Given this list of marker genes H2AC4, H4C2 (NCBI Gene Id 8366), H4C16, H4C6, H4C11, H4C14, H4C12, H4C8, H4C15, H4C9, H4C13, H4C5, RCC2, H2BC11, H4C4, H4C1, H4C3, H2AC8, CENPA, here is a description of the gene set: Human Gene Set: GOCC_CHROMOSOME_CENTROMERIC_CORE_DOMAIN studied in species Homo sapiens The innermost portion of the centromeric region of a chromosome, encompassing the core region of a chromosome centromere and the proteins that bind to it.